Given this list of marker genes Ripor1, Ripor2, Epha4, Gpsm1, Stmn1, Met, Tns3, Ccpg1, here is a description of the gene set: studied in species Mus musculus Mouse Gene Set: GOBP_REGULATION_OF_GUANYL_NUCLEOTIDE_EXCHANGE_FACTOR_ACTIVITY Any process that modulates the frequency, rate or extent of guanyl-nucleotide exchange factor activity.